Given this list of marker genes Slurp1, Ptk2b, Ly6g2, Psca, Ly6h, Slurp2, Ly6c2, Spdye4b, Lypd6b, Ly6i, Lynx1, Ly6m, Lypd1, Cdk5, Ly6c1, Ly6a, Ly6g6e, Ly6g, Agrn, Tmem35a, Spdye4a, Lypd6, Pate4, Ly6g6d, Ly6e, Ly6f, Ly6g6g, here is a description of the gene set: species: Mus musculus Mouse Gene Set: GOMF_NEUROTRANSMITTER_RECEPTOR_REGULATOR_ACTIVITY A molecular function that directly (via physical interaction or direct modification) activates, inhibits or otherwise modulates the activity of a neurotransmitter receptor. Modulation of activity includes changes in desensitization rate, ligand affinity, ion selectivity and pore-opening/closing.